The following is a description of a gene set: studied in species Homo sapiens Any process that stops, prevents, or reduces the frequency, rate, or extent of leukocyte mediated immunity. Human Gene Set: GOBP_NEGATIVE_REGULATION_OF_LEUKOCYTE_MEDIATED_IMMUNITY, and this is the list of marker genes: GRB2, IL4I1, SMAD7, HLA-A, PTPRC, CRK, HLA-G, SERPINB9, TBX21, NDFIP1, HAVCR2, KLRD1, NECTIN4 (nectin cell adhesion molecule 4), C4BPA, CD274, CLEC12B, IL20RB, NECTIN2, FOXJ1 (NCBI Gene Id 2302), IL13RA2, KLRC1, KIR2DL4, SLAMF1, JAK3, USP5, HLA-E (major histocompatibility complex, class I, E), CD84, SERPINB4, LILRB1, CX3CR1, PARP3, XCL1, IL7R, IFNA2, FOXP3, HLA-B (major histocompatibility complex, class I, B), CR1L, DUSP22, IFNB1, INPP5D, BCL6, MAPK3, CR2, TIGIT, HFE (homeostatic iron regulator), FCGR2B, BST2, BCR, ARG1, PPP3CB, CCR2, CD96, LGALS9, SPI1, SPN, AHR, CD46, PVR, LILRB4, HLA-F, MICA, SUSD4, CR1, CD80, FOXF1, TGFB1, CEACAM1, CLEC4G, RABGEF1, ARRB2, NCKAP1L, PTPN6, C4BPB, UFL1, PDCD1, CD300A